Given this list of marker genes Nr2f2, Itgav, Gjb5, Hand1, Elf5, Cts7, Lif, E2f7, Snai1, Senp2, Plk4, Plg, Prdm1, E2f8, Hectd1, Sox15, Mdfi, Cts8, Erf, here is a description of the gene set: Mouse Gene Set: GOBP_TROPHOBLAST_GIANT_CELL_DIFFERENTIATION studied in species Mus musculus The process in which a relatively unspecialized cell acquires specialized features of a trophoblast giant cell of the placenta. Trophoblast giant cells are the cell of the placenta that line the maternal decidua.